Given this list of marker genes Ltf, Tlr1, Dhx33, Tifab, Cd300e, Fpr-rs7, Nfkbil1, Cnot7, Mettl3, Lep, Tlr7, Serpinb9b, Nfkbiz, Nlrp4f, Cd160, Rps19, Nlrp4e, Casp6, Nlrp1b, Ifi214, Serpinb9, Trim5, Cd300c2, Usp15 (ubiquitin specific peptidase 15), Scimp, Hsp90aa1, Lyar, Slc15a3, Brcc3dc, Lgr4, Sarm1, Epg5, App, Trim56, Klrc3, Usp17le, Raet1e, Ifih1, Tnip3, Sh2d1b1, Lgals9 (NCBI Gene Id 16859), Zcchc3, Dhx9, Plscr1 (phospholipid scramblase 1), Becn1, Dhx58, Serpinb9d, Clec12b, Mbl2, Irf7, Ankrd17, Slc19a1, Mapkapk3, Cdc37, Ulbp1, Ipo5, Aars2, Nploc4, Pla2g5, Pcbp2, Klrb1, Oas1e, S100a9, Tkfc, Smpdl3b, Polr3b, Appl1, Alpk1 (NCBI Gene Id 71481), Stmp1, Nr1d1, Ffar2, Rtn4, Dab2ip, Syk, Smim30, Fadd, Lyplal1, Zc3hav1, Dtx4, Sfpq, Tlr8, Ptpn6, Aurkb, Trem2, Isg15, Fam3a, Tnf, Mndal (myeloid nuclear differentiation antigen like), Serpinb9e, Sqstm1, P2rx7, Polr3f, Cd300c (NCBI Gene Id 387565, CD300C molecule), Map3k7 (NCBI Gene Id 93774), Fbxl2, Akirin2, Peli1, Zdhhc5, Nlrp4c, Pycard, Arf6, Cd300ld3, Gpr108 (NCBI Gene Id 98067), Lsm14a, Lag3, Irak1, Myd88, Trim30b, Ticam2, Polr3g, Fosl1, Klrk1, Sting1, Slc46a2, Flot1, Cd300lf, Med1, A2m, Oas1h, Cactin, Ufd1, Tlr2, Ifi206, Cgas, Nlrc3, Rab11fip2, Ceacam1, Pum2, Serpinb9c, Ywhaz, Il12a, N4bp1, Gdi1 (NCBI Gene Id 14567), Rsad2, Tap2, Trim12c, Trafd1, Ptpn2 (protein tyrosine phosphatase, non-receptor type 2), Pparg, Lrrc14, H2-T23, Dnaja3, Hspa8, Prkdc, Spsb3, Ifi203, Serping1, Oas1g, Rela, Ly96, Fpr2 (formyl peptide receptor 2), Nono, Otop1, Pik3ap1, Tlr4, Trim12a, Casp4, Rasgrp1, Traf3ip3, Zdhhc4, Fcnb, Tnip1 (TNFAIP3 interacting protein 1), Ticam1, Gbp2, Nr1h3, Pja2, Tgfb1, Irak2, Casp1 (caspase 1), Trim3, Prkce, Mul1 (mitochondrial ubiquitin ligase activator of NFKB 1), Pqbp1, Aim2, Lacc1, Chuk (NCBI Gene Id 12675), Raet1d, Il18rap, Tifa, Myo1f, Cpt1a, Gramd4, Naglu, Tarbp2, Gps2, Usp27x, Sirt2, Rbm47, Rnf115, Stat5a, Gimap5, S100a8, Oas1f, Slc15a4, Tlr6 (toll-like receptor 6), Casp8, Pik3r6, Nlrp6, Tomm70a, Kcnj8, Adar, Cd74, Nlrx1, Gkn2, Slamf6, H2-M3, Trim30d, Tril, Ifi213, Lrp8, Peli3, Hmgb2, Reg3g, Lamp2, Dusp10, Mapk8, Gbp2b, Rnf135, Nod1, Zdhhc9, Tirap, Hpx, Tmem126a, Spi1, Cd274, Ncr3-ps (NCBI Gene Id 674165), Znrf1, Rigi, Ccdc134, Usp18, Ifi208, Gfi1, Ap1g1, Gbp5, Nfe2l2, Clpb, Inpp5d, Trim30a, Tlr11, Trim30c, Ogt, Clnk, Sin3a, Rps6ka3 (ribosomal protein S6 kinase polypeptide 3), Fgr, Cep63, Klri2, Pim1, Klrc2, Tlr13, Polr3d, Rnf144a, Hspa1b, Letmd1, Il21, Ap3b1, Klrc1, Txk, Banf1, Clec4n, Trim15, Cadm1, Fpr-rs3, Usp50, Atg12, Usp29, Pdpk1, Washc4, Clec2d, Lrrc19, Sfn, Ttll12, Trex1, Adam8, Drd2, Mark4, Tasl, Xrcc5, Wnt5a, Srebf1, Fcna, Trim25, F2rl1, Ubqln1, D1Pas1, Klre1, Erbin, Klrb1a, Gbp7, Ywhae, Il12b, Nectin2, Tspan6, Ube2k (ubiquitin-conjugating enzyme E2K), Ripk2, Oasl1, Lrrfip2, Usp38, Lats2, Hexim1, Sh2d1a, Ppt1, Ddx3x, Zdhhc18, Mmp12, Cd36, Tab1, Nlrc5, Rbm14, Tnfaip3, Ccr1, Slamf8, Ifi209, Nr1h4, Nlrp3, Cptp, Susd4, Tnip2, Nagk, Klrb1f, Samhd1, Calhm6, Ikbke, Cd226 (NCBI Gene Id 225825), Kat5, Klrb1c, Stat5b, Irgm2, Trim6, Vsig4, Trim41, Tax1bp1, Eif4e2 (NCBI Gene Id 98625), Rnf34, Igtp, Irgm1, Irf3, Irf1, Irak3, Fpr-rs6, Ythdf2, Ereg, Nfkbia, Nek7, Mfhas1, Ptgs2os, Bcl10, Lyn, Nlrp4b, Elp6, Arg1, Cfhr4, Ecsit, Treml4, Cd300a, Cd96, Xiap, Nmi, Rasgrp4 (RAS guanyl releasing protein 4), Nop53, Gfer, Trim21, Ythdf3 (YTH N6-methyladenosine RNA binding protein 3), Crtam, Ddx60, Nlrc4, Rnf125, Nlrp4a, Cd86, Mavs (NCBI Gene Id 228607), Abhd17a, Cav1, Atg5, Smpdl3a, Kcnk13, Prkd1, Znrf4, Serpinb9f, Serpinb9g, C1qbp, Gm12250, Unc93b1, Pum1, Vav1, Fpr-rs4, Oas1c, Arrb2 (NCBI Gene Id 216869), Ifi205, Parp9, Colec12, Gigyf2, Zdhhc3, Tyrobp, Clec7a (NCBI Gene Id 56644), S100a14, Csnk1a1 (casein kinase 1, alpha 1), Lats1, Grn, Gimap3, Btk, Tlr5, Slc15a2, Lamp1, Phb1, Ppp2ca, Oas1d, Cd14, Klri1, Mefv, Lrch4, Polr3c, Havcr2, Trem3, Hspd1, Card9, Ifi35, Ncf1, Traf3, Bpifb1, Cyba, Sh2d1b2, Ins2, Ninj1, Tlr3, Phb2, Trim32, Gm15441, Ddx39a, Matr3, Gbp3, Otud4, Rab7b, Mill1, Cfh, Serpinb9h, Itch, Pik3r1, Klrd1, Oas1b, Ins1, Dcst1, Hcfc2, Hmgb1, Tap1, Znfx1, Apoe, Nlrp1a, Ppp6c, Otulin, Zdhhc1, Brcc3, Oas1a, Inava, Gpatch3, Nectin4, Tlr12, Appl2, Zdhhc12, Ifi207, Klrb1b, Grb2, Tyro3, Trim11, Ifi211, Zbp1, Oas3, Pvr, Ptpn22, Trim62, Irf2, Xcl1, Riok3, Irf4, Pspc1, Clec4e, Ifi203-ps, Rnf170, Stat2, Ptprs, Esr1, Wdfy1, Parp1, Tlr9, Nod2, Dpp4, Traf6, Nlrp10, Lbp, Ifi204, Src, Atat1, Trim31, Parp14, Tbk1, Crk, Eif2ak2, Rftn1, Akt1, Mapkapk2, Acod1, Xrcc6, Sec14l1, Igf2, Rnf185, Serpinb1a, Plcg2, here is a description of the gene set: Any process that modulates the frequency, rate or extent of the innate immune response, the organism's first line of defense against infection. studied in species Mus musculus Mouse Gene Set: GOBP_REGULATION_OF_INNATE_IMMUNE_RESPONSE